The following is a description of a gene set: Human Gene Set: REACTOME_TRAF6_MEDIATED_IRF7_ACTIVATION species: Homo sapiens TRAF6 mediated IRF7 activation, and this is the list of marker genes: TRIM4, IFIH1, IFNA5, IRF3, IFNA21, IFNA14, IKBKE, IRF7, IFNA10, CREBBP, IFNA7, SIKE1, IFNA4, IFNA6, RIGI, TRAF6, TRIM25, TBK1, TANK, IFNA16, EP300, IFNA8, IFNB1, IFNA2, IFNA1, TRAF2, RNF135, IFNA13, IFNA17, MAVS